Given this list of marker genes Ptbp1, Tnfrsf1a (NCBI Gene Id 21937), Cxcr2, Csf2rb, Il6, Igfbp6, Timp2, Plau, Selplg, Bmp2 (NCBI Gene Id 98992), Serpine1, Egf, Serpine2, Acvr1b, Edn1, Csf2, Fas, Plaur, Scamp4 (secretory carrier membrane protein 4), Spx, Mmp9, Pgf, Tubgcp2, Gmfg, Gem (NCBI Gene Id 14579), Ccl24, Bmp6, Ctsb, Axl, Serpinb3c, Il6st, Igf1, Igfbp2, Ccl5, Tnf, Angpt1, Cxcl12, Igfbp5, Mif, Hmgb1, Mmp13, Mmp14, Pappa, Igfbp4, Il7, C3, Csf1, Tnfrsf1b, Ang, Icam5, Mmp10, Rps6ka5, Fgf7, Icam1, Ccl20, Cxcl3, Ccl1, Cxcl16, Cd55, Ccl8, Cxcl10, Ctnnb1, Nap1l4, Mmp3, Mmp2, Gdf15, Il2, Itpka (inositol 1,4,5-trisphosphate 3-kinase A), Wnt16, Il1a, Igfbp7, Ccl2, Angptl4, Sema3f, Hgf, Ereg, Vegfc, Dkk1, Inha, Tnfrsf11b, Pigf, Fgf1, Igfbp1, Esm1, Il15, Ptger2, Ccl26 (C-C motif chemokine ligand 26), Pecam1 (NCBI Gene Id 97748), Igfbp3, Itga2, Spp1, Jun, Mmp12, Ets2, Il13, Cd9, Ccl4, Ccl7, Cxcl1, Iqgap2, Wnt2, Cxcl2, Ccl3, Areg (NCBI Gene Id 11839), Vegfa, Ptges, Fgf2, Kitl, Il10 (interleukin 10), Egfr, Bex3, Il18, Vgf, Lcp1, Plat, Il1b, Nrg1, here is a description of the gene set: Genes upregulated in senescent cells: Senescence-associated secretory phenotype (SASP). Mouse Gene Set: SAUL_SEN_MAYO from publication Saul D, Kosinsky RL, Atkinson EJ, Doolittle ML, Zhang X, LeBrasseur NK, Pignolo RJ, Robbins PD, Niedernhofer LJ, Ikeno Y, Jurk D, Passos JF, Hickson LJ, Xue A, Monroe DG, Tchkonia T, Kirkland JL, Farr JN, Khosla S (PMID 35974106) Although cellular senescence drives multiple age-related co-morbidities through the senescence-associated secretory phenotype, in vivo senescent cell identification remains challenging. Here, we generate a gene set (SenMayo) and validate its enrichment in bone biopsies from two aged human cohorts. We further demonstrate reductions in SenMayo in bone following genetic clearance of senescent cells in mice and in adipose tissue from humans following pharmacological senescent cell clearance. We next use SenMayo to identify senescent hematopoietic or mesenchymal cells at the single cell level from human and murine bone marrow/bone scRNA-seq data. Thus, SenMayo identifies senescent cells across tissues and species with high fidelity. Using this senescence panel, we are able to characterize senescent cells at the single cell level and identify key intercellular signaling pathways. SenMayo also represents a potentially clinically applicable panel for monitoring senescent cell burden with aging and other conditions as well as in studies of senolytic drugs. studied in species Mus musculus